The following is a description of a gene set: species: Homo sapiens Any process that results in a change in state or activity of a cell or an organism (in terms of movement, secretion, enzyme production, gene expression, etc.) as a result of a tumor necrosis factor stimulus. Human Gene Set: GOBP_RESPONSE_TO_TUMOR_NECROSIS_FACTOR, and this is the list of marker genes: CEBPA, HAS2, TANK, PTK2B, THBS1, POSTN, TNFSF13B, BIRC7, OTULIN, MIR125B1, NR1D1, PRPF8, SLC2A4 (NCBI Gene Id 6517), ST18, TRAF1, CASP4 (NCBI Gene Id 837), HYAL1, MIR31, ACOD1, FABP4, RPS3, UBE2K, ADAM10, CIB1, BIRC2, MYOD1, CRHBP, CASP1, BRCA1, ANKRD1, GAS6, MAPK3, NOL3, CD58, ERBIN, PYCARD, TXNDC17, NMNAT3, MIR181B1 (microRNA 181b-1), TNFSF11 (TNF superfamily member 11), SPATA2, EDN1, BIRC3, ZC3H12A, ACTN4, MYOG, ZFP36, PCK2, ARHGEF2, GSDME, LAPTM5, INPP5K (NCBI Gene Id 51763), RORA, SYK, ABCB1, SMPD1, ZNF268, NKX3-1, TNFRSF11B, MAP4K3, MIR1246, MIR766, ZFAND6, RELA, AKT1, SMPD4, NKIRAS1, NR2C2, DCSTAMP, PTPN2, PPP2CB, TNFRSF21, ADAM17, COMMD7, HYAL2, CYBA, TUBA1A, TNFRSF11A, TNFAIP3, ZNF675, STAT1, TNFSF18, GSTP1, SHARPIN, MIR21, SELE (selectin E), JAK2, CHI3L1, TNFRSF1B, MMP8 (NCBI Gene Id 4317), BAG4, TNFRSF1A, SPPL2A, CPNE1, GBP3, MIR30C2, FOS, NLRP2B, KLF2, LCN2, AKAP12, ASAH1, SNRNP70, SIRT1 (NCBI Gene Id 23411, sirtuin 1), NRDC, TRAF3, F2RL1 (NCBI Gene Id 7901), CCL2, GPS2, IL18BP, GPD1, NKIRAS2, HSPA1A, CAMP, LIMS1, PYDC2, CCL5, YBX3, NAIP, HMHB1 (NCBI Gene Id 57824), SMPD3, TRAF5, MAPKAPK2, TNFRSF25, TNFRSF14, DICER1 (NCBI Gene Id 4333), ULK1, PIAS4, ENDOG, RIPK1, AFF3, PLVAP, HYAL3, NR1H4, CCL3, EDA2R, MAPK1, EXT1, GATA3, CALCA, TRAF3IP2, HES1, UBD, TRAIP, H2BC11, DAB2IP, XIAP, FOXO3, TNFRSF17, FAS, CHUK, MIR20B, IGBP1, ZFP36L1, CARD16, NFKBIA, CLDN18, CD40 (NCBI Gene Id 958), PELI3, GBP1, NUB1, CYLD, NFE2L2 (NCBI Gene Id 4780), MIR27B, MAP3K5, TP53, MIR24-1, KAT2A, GPER1, CASP3, TNFRSF13C, RRAGA, SPHK1, TMC8, PYDC1 (pyrin domain containing 1), ADAMTS12, RFFL, TRAF6, NPNT, SPPL2B, CARD8, TRADD, SLC22A5, TRIM32, GBA1, MIB2, MIR130A, YTHDC2, FOXP1, CARD14, VCAM1, TNF, EIF5A, KRT8, CRIPTO, SFRP1, PRKN, ZFP36L2, ADAMTS13, MAP2K7, ADAMTS7, MIR152, UMOD, AIM2 (NCBI Gene Id 9447, absent in melanoma 2), KRT18, MIR142, ADAM9, CXCL16, CD70, TAX1BP1 (NCBI Gene Id 8887), HIPK1, TMSB4X (thymosin beta 4 X-linked), OCSTAMP, FCAR, ANXA4, MAPK14, NFKB1, PID1, ADIPOQ, GCH1, GBP2, TNFRSF19, PIAS3, NSMAF, APOA1, MIR34A, TRAF2, COL1A1, TNFRSF18, IKBKB, CFL1, CLDN1, TNFRSF4, ASS1, CDK5R1, CCDC3, ILK, MAP3K7, TIFA, CXCL8, CASP8, CACTIN, HSPA1B